The following is a description of a gene set: studied in species Mus musculus Genes positively differentially expressed in cell type: cDC2 (conventional dendritic cell type 2) upon treatment with cytokine: IL-3 in mouse lymph nodes in vivo. from publication Cui A, Huang T, Li S, Ma A, Pérez JL, Sander C, Keskin DB, Wu CJ, Fraenkel E, Hacohen N (PMID 38057668) Mouse Gene Set: CUI_CDC2_IL3_RESPONSE_UP Cytokines mediate cell-cell communication in the immune system and represent important therapeutic targets. A myriad of studies have highlighted their central role in immune function, yet we lack a global view of the cellular responses of each immune cell type to each cytokine. To address this gap, the authors created the Immune Dictionary, a compendium of single-cell transcriptomic profiles of more than 17 immune cell types in response to each of 86 cytokines (>1,400 cytokine-cell type combinations) in mouse lymph nodes in vivo. A cytokine-centric view of the dictionary revealed that most cytokines induce highly cell-type-specific responses. For example, the inflammatory cytokine interleukin-1β induces distinct gene programmes in almost every cell type. A cell-type-centric view of the dictionary identified more than 66 cytokine-driven cellular polarization states across immune cell types, including previously uncharacterized states such as an interleukin-18-induced polyfunctional natural killer cell state., and this is the list of marker genes: Pdcl3, Psma4, Tma7, Cdkn1a, Napsa, Tuba1b, Psmb7, Snd1, Batf3, Htr7, Pgk1, Psmd12, Magoh, Wdr18, Sf3b3, Socs3, Ssb (small RNA binding exonuclease protection factor La), Rab7, Lsm12, Srsf2, Hnrnpa2b1, Serpina3g, Nubp1, Ffar2, Psmc5, Ggct, Psmd14, Adgre5, Ly86, Gabarap, Lsm7, Sar1a, Ngfr (NCBI Gene Id 18053), Pa2g4, Ube2d3, Rogdi, Arpc5, Reep3 (NCBI Gene Id 28193), Denr, Fkbp1a, Xbp1, Uqcrc1, Polr2g, Diaph1, Ranbp1, Ppp1r14a, Cd24a, Ywhae (NCBI Gene Id 22627), Psmd2, Apex1, Arl1, Sdad1, Anp32e, Bcl2a1d, Mgl2, Sdhc, Pkm, Atp5pb, Apod, Fh1, Rras2 (related RAS viral (r-ras) oncogene 2), Foxn3, Fcgr2b, Lims1, Cox6b1, Kmo, Ptpn4, Slc35b1, Lgals1, Mbd2, Smdt1, Ddx39a, Dad1 (NCBI Gene Id 13135), Abce1 (ATP-binding cassette, sub-family E member 1), Ndufb9, Cct5, Cox8a, Arpc1b, Ikzf1, Prelid3b, Fabp5, Ldha, Ube2m, Tmem131, Cct3, Abracl, Prmt1, Mrps14, Mif, Mkrn1, Bzw2, Srgn, Ost4, Prex1, Olfm1, Timm17a, Cope, Gbp7, Arl8b (NCBI Gene Id 69275), Fcgrt, Il4i1, Sf3b6, Bcl7c, Psmd4, Exosc3, Fem1c, Mrps28, Prpf31, Basp1, Ube2n, Atp5pf, Ndufb8, Runx3, Tardbp, Csf2rb, Enah, Cdk2ap2 (NCBI Gene Id 67777), Arf5, S100a6, Cyrib, Malt1, Eno1, Tspo, Ubtf, Snrpc, Runx1, Gars1, Efhd2, Cd53, Aco2, Gtf3c6, Hnrnpab, Ppa1, Psmb2, Cct8, Psma2, Ppp1r14b, Atp5f1b, Edem1, Pfdn4, Orai1, Eif4a1, Ckb, Tpm3, Ddx18, Zfp593, Set, Mrpl54, Ccdc115, Bax, Sec61g, Eif5a, Psmd1, Phb1, Edf1 (endothelial differentiation-related factor 1), Cops7a, Hspd1, Cyp4f16, Psmb4, Ndufa12, Trap1, Nr2c2ap, Myl12a, Fyn, Bcl2a1b, Rbx1, Rap2a, Tnfrsf13b, Fscn1, Cyb5r3, Mrpl12, Cfl1, Ddr1, Lrrk1 (leucine-rich repeat kinase 1), Psmb8, Tagln2, Sinhcaf, Eef1g, Prelid1, Ppm1m, Cbfa2t3, Nr4a3, Ptpn1, Ccl17, Tmem131l, Nrp2, Rrp1, Pfn1 (NCBI Gene Id 18643), Ppp1ca, Pfkp, Srp9, Ass1, Rap1a, Ndufb7, Tomm40, Macroh2a1, Pacsin2 (protein kinase C and casein kinase substrate in neurons 2), Psma7, Ncl, Gfra2, Eva1b, Mgat2, Ndufa8, Ssr2, Bcl2l14, Prkcd, Plet1, Arhgdia, Cltc, Timm8b, Sfxn1, Cstb, Atp6v1g1, Pfdn6, Ms4a4c, Sec61b, Spcs2, Ece1, Llph, Kif1a, Ifi35, Plac8, Emc6, Rab14, Uck2, Dnajc2, Atp5mc1, Coro2a (coronin, actin binding protein 2A), Cd209a (NCBI Gene Id 170786), Ebna1bp2, Cd209e, Naaa, Psma3, Mrpl20 (NCBI Gene Id 73950), Mtmr4, Rbm3, Cox17, C1qbp, Wdr1, Casp8, Vps53 (NCBI Gene Id 69840), Tubb4b, Wdfy4, Necap2, Cst3, Bzw1, Nme1, H2-DMb2, Psmb6, Eif6, Rab24, Cdh1, Adam19, Rexo2, Vcp, Dok1, Hnrnpa3, Myo1g, AA467197, Sesn2, Pdcd5, Tomm5, Nfkb1, Clec4n, Ewsr1, Ifitm1, Eps8, Sdc4, Pnp, Txnl4a, Cops5, Mthfs, Mpc1, Hspa4, Hnrnpk, Tspan13, Rwdd1, S100a4, Rara (NCBI Gene Id 19401), Ms4a6d, Dlst, Mdh2, Tns1, Lta4h, Kcnk6, Akt1, Nhp2, Dynll1, Syngr2, Eif2s1, Vim, Adam23, Cish, Snx3, Gnb4, Cyp7b1, Irf5, Vasp, Cyc1, Gpr183, Snap23, Sh3bgrl, Adam8, Bcl2a1a, Plpbp, Serp1, Nsun2, Tes, Fbl, Ostc, Gpr35, Nckap1l, Uqcrb, Spi1, Phb2, Slfn2, Timm13, Jak2, Snrpa1, Snrpd1 (small nuclear ribonucleoprotein D1, NCBI Gene Id 99147), Tet2, Cd48, Nfu1, Cox7b, Septin3, Mettl1, Lcp1, Srrt, Srp14, Pno1, Oaz1, Ran, Ncbp3, Bag1, Gapdh, Chchd1, Araf, Jaml, Car2, Srsf9, Dok2, Myl6, Litaf, Arpc2, Aamp, Hsd11b2, Psmb5, Vrk1, Adpgk, Chmp2a, Srm, Pdia6, Spint1, Scimp, Emg1 (EMG1 N1-specific pseudouridine methyltransferase), Krcc1, Gar1, Ndufs4, Socs2, Sppl2a, Twf2, Clec10a, Ciita